The following is a description of a gene set: species: Homo sapiens Genes down-regulated in comparison of monocytes treated with anti-TREM1 versus untreated monocytes. from publication Dower K, Ellis DK, Saraf K, Jelinsky SA, Lin LL (PMID 18292579) Human Gene Set: GSE9988_ANTI_TREM1_VS_VEHICLE_TREATED_MONOCYTES_DN TREM-1 is an orphan immunoreceptor expressed on monocytes, macrophages, and neutrophils. TREM-1 associates with and signals via the adapter protein DAP12/TYROBP, which contains an immunoreceptor tyrosine-based activation motif (ITAM). TREM-1 activation by receptor cross-linking is pro-inflammatory, and can amplify cellular responses to Toll-like receptor (TLR) ligands such as bacterial lipopolysaccharide (LPS). To investigate the cellular consequences of TREM-1 activation, we have characterized global gene expression changes in human monocytes in response to TREM-1 cross-linking in comparison to and combined with LPS. Both TREM-1 activation and LPS up-regulate chemokines, cytokines, matrix metalloproteases, and PTGS/COX2, consistent with a core inflammatory response. However, other immunomodulatory factors are selectively induced, including SPP1 and CSF1 (i.e., M-CSF) by TREM-1 activation and IL-23 and CSF3 (i.e., G-CSF) by LPS. Additionally, cross-talk between TREM-1 activation and LPS occurs on multiple levels. While synergy in GM-CSF protein production is reflected in commensurate mRNA abundance, comparable synergy in IL-1b protein production is not. TREM-1 activation also attenuates the induction of some LPS target genes, including those that encode IL-12 cytokine family subunits. Whereas positive TREM-1 outputs are abolished by the PI3K inhibitor wortmannin, this attenuation is largely PI3K-independent. These experiments provide a detailed analysis of the cellular consequences of TREM-1 activation, and highlight some of the complexity in signal integration between ITAM- and TLR-mediated signaling., and this is the list of marker genes: LILRB1, GRK3, MAPK14, KLF13, SYK, TWF2, LTBP2, ARL6IP5, BMF, PIK3AP1, POU2F2, PIK3R5, TFEB, C1orf162, RASSF5, SIN3A, PTAFR, HCK, PSAP, AMPD2, TGIF2, KLHDC3, LGALS1, WDR44, ARHGAP30, DSTYK, CORO1A, ULK1, GRN, UBE4B, FPR3, MYO1F, ANKRD13A, STX6, MAVS, HDGF, NLRP12, SMAD3, MAP7D1, PPM1F, CALHM2, HECA, ZNF44, CCNG2, CTSH, PIK3CD, ARHGAP27, MLXIP, MAP3K3, CCR2, GABARAP, TCF20, INTS9, PECAM1 (platelet and endothelial cell adhesion molecule 1), GIMAP1, GNB2, RUNX3, TLR1, TCHP, MR1, GIMAP8, ELOVL1, SEC14L1, APOL3, IL10RA, LILRB2, POU2F1 (NCBI Gene Id 7823), CTDSP2, PAIP2, CCM2, YWHAB, TRIM8, DEPDC5, SMARCAL1, RAC1, ARHGAP45, DHX57, RASSF2, TTC7A, STK24, WIPI2, MIDEAS, MYD88, TGFBR2, USB1, RPS6KA1, DAGLB, SUN2, RHOG, FAM78A, MAST3, NISCH, IKBKE, CRTC3, CSF1R, TNRC6A, ARHGAP22, SAP30, RRM2B, NT5DC2, SGK3, DDX17, NCOA4, CSK, TOR1B, DCAF12, USP19, MGAT4A, ARPC1B, PPP1R9B, MPEG1, ARRDC2, ZNF652, NECTIN2 (nectin cell adhesion molecule 2), NFAM1, ATXN7L3, SORL1, MARCKSL1, PTTG1IP, CXCL16, IL27RA, ARL3, CFP, FAM89B, ARRB1, ZNF780A, CLIC1, AKNA, SH2D3C, MRTFB, NCKAP5L, FUCA1, LRG1, ZNF710, PINK1, TNFAIP2, RGS19, CD14, PCBD2, ZNF740, EFHD2, KIF3B, IFNGR2, SETD1B, GLTP (NCBI Gene Id 51228), ACP5, CTNND1 (NCBI Gene Id 82168), SYNE3, DENND11, MAPK1, TRAPPC12, SASH3, ATF5, TRADD, PTP4A2, BRD3, NUP214, CYBB, COTL1, TACC1, TACC3, DYNLL1, ILK, ZDHHC7, CMTM3, PRELID1, NDST1, ZFP36L2, NAGS, TNRC18, DUSP7, BCL9L, GAPT, FRAT1, ARHGAP1, EMSY, IFFO1, PLXNB2, ORAI2 (NCBI Gene Id 84917), MIA2, SIPA1, TNFAIP8L2 (TNF alpha induced protein 8 like 2), STK38, GPR107, CYTIP, BCL3, GIT2, TGFBI, WBP1L, ENG, NCOA3, SUMO2, MRTFA, GAL3ST4, GRB2, EVI2A, STK11